The following is a description of a gene set: The presence of immunoglobulin A deposits in the glomerulus. Human Gene Set: HP_IGA_DEPOSITION_IN_THE_GLOMERULUS studied in species Homo sapiens IgA deposition in the glomerulus, and this is the list of marker genes: NUP107, SPRY2, MMP1, COL7A1, UMOD